The following is a description of a gene set: Human Gene Set: GSE39820_TGFBETA1_IL6_VS_TGFBETA1_IL6_IL23A_TREATED_CD4_TCELL_DN studied in species Homo sapiens Genes down-regulated in comparison of CD4 T cells treated with TGFB1 and IL6 versus those treated with TGFB1, IL6 and IL23A. from publication Lee Y, Awasthi A, Yosef N, Quintana FJ, Xiao S, Peters A, Wu C, Kleinewietfeld M, Kunder S, Hafler DA, Sobel RA, Regev A, Kuchroo VK (PMID 22961052) TGF-beta3 produced by developing Th17 cells induces highly pathogenic T cells that are functionally and molecularly distinct from TGF-beta1-induced Th17 cells. The microarray data represent a distinct molecular signature for pathogenic versus non-pathogenic Th17 cells., and this is the list of marker genes: PPM1N, PFDN1, PRIM1, GAR1, LY6E, TM2D3, SARNP (SAP domain containing ribonucleoprotein), ISCA2, CBX4, PHLDA3, MAN1A1, RPS27L, PRPF38A, UQCC6, IL5RA, LUM, GINS4, AFP, GRHPR, CD74, TRMT112, CAV2, BOLA1, DTWD1, MICOS13, LAG3, BANP, TRNAU1AP, DRAP1, NPM3, TAT, MRPS28, BCAS2, NDUFB4, ASCC1, AKR1B15, GPR171 (G protein-coupled receptor 171), HADH, EYA4, FUS, ADH5, NFIB, UTP11, AQP5, NSG2, MRPL57, MR1, MIX23, IRAK1BP1, TECR, TIMM8B, IDNK, MED27, STRA8, SSU72 (NCBI Gene Id 79588), TPGS1, XRCC6, MRPS31, MRPL2, ISY1, SCNM1, CHURC1, CHRNE, UBE2I, MRPS16, NDUFS2, GLRX, FH, GALT, PFKFB2, MZT2B, ALKBH5, PSMG1, UPK1A, POP5, RIMBP3C, SNRPD3, PYCARD, SOCS1, GLO1, LIN28B, NDUFS3, PLA2G12A, IGDCC4, MRPL36, GRHL3, C19orf53, ZNF248, POLR1H, BID, MPC1, LSM10, MRPL21, GLIPR1, PARD3B, NAA20, MRPS15, IFI30, FAM98C, SPRY1, CNPY3, ECHS1, IL1RL2 (interleukin 1 receptor like 2), VEZT, EVL, RAP2B, TSSC4, PSMG2, CXCR3, UTP14A, CASP6, ZNF219 (NCBI Gene Id 54166), LYRM4, CRABP2, PTRH2, BHLHE40, KGD4, AARSD1, LGALS3BP, TMEM60, GSTO2, SFMBT2, NOP10, NDUFA7, SIGIRR, FIS1, MRPL16, NKAIN4, PTPRCAP, HS3ST3A1, QTRT1, DAPL1, IL22, PSMB7, CD247, MCRIP2, LSP1, THG1L, CD3G, MRPL32, FXYD1, SERPINB9, RRAGA, FARS2 (phenylalanyl-tRNA synthetase 2, mitochondrial), DYNLRB1, DTYMK, OLA1, MYO15A, UQCRQ, RAC2, STK26, ADPRM, BANF1, KEL, TPBG, PLXNC1, MAP3K10 (NCBI Gene Id 4294), NUBPL, SELENBP1, PHB1, ATG3, UQCR10, BNIP1, PTGS2, CIAO2B, SNRNP27, ALDH1L2, HAT1, LORICRIN, ZNF524, PRAM1, PRRT4, POMP, RAMP3, ALAD, PSMG4, SNRPF, WASHC3, MRPS14, TOMM22, CAPZB, PDSS2, POLR2E, ELOVL5, MYL4, TRIM47, UNG, GPR183, RAB43, GALR3, HIGD2A (NCBI Gene Id 90241), DCTPP1, MED30 (mediator complex subunit 30), FMC1, KRT18, PRDX2, HMCES, ACSL6, RIMS4, NFKBIB